The following is a description of a gene set: studied in species Homo sapiens Lip pit Human Gene Set: HP_LIP_PIT A depression located on a lip., and this is the list of marker genes: TP63, KDM6A, RIPK4, EYA1, NECTIN1, SIX1, OFD1, IRF6, SMO, KMT2D, GRHL3, MSX1, TFAP2A